Given this list of marker genes KRTAP20-2, CBX6, CDIPT, CNTN2, NAA60, BORCS6, LAMA3, IL22, HOXA2, SSH3, BMAL1, NR1D1, PAX6 (paired box 6), SZT2, HOXC5, GJC1, PTBP3, SLC7A10, INO80, IER5, MIR22HG, TRIB1, PHPT1, LHX6, HYAL2, YRDC, RFX5 (NCBI Gene Id 5993), FHL2 (NCBI Gene Id 2274), IL10, KRT72, ALDH3A1, DSCAM, BIRC3, KCNQ4, LINC03122, NKRF, CLUL1, CCKAR, BCL6, OSBPL6, MPP2, EDEM1, SFRP1, ABCA1, WDFY2, HMG20B, PLAG1, ADD3, HEXD, NR4A1, ACACA, SRF, CEP95, SLC9A9, EMILIN1, CDC14A, DDX5, MAPK10, RNF44, ADAMTS5, HOXD8, SGCA, KDELR2, ACTG2, ACTR1B, VAMP2, ENTR1, NLGN3, DPF3 (NCBI Gene Id 8110), SMARCB1 (NCBI Gene Id 6598), TSPAN3, PMEPA1, KLC2, HAND2, ABCG4, INPPL1, GPC3, NEUROD6, KTN1 (kinectin 1), WDR81, MMP20, TFAP4, ROCK2, DTX1, H2AZ1, CHRDL1, DCP1A, ZBTB47, SIX1, OGFOD3, TMEM38A, ETV6, CHD4, ARHGEF25, ID3, PELO, GSC, YWHAZ, GPX2, IFRD1, TSC22D3, TRPC5, ATP2A2, TBCC, CKAP4, BHLHE22, CRYAB, CDH3, RNF38, MEIS1, CDC25B, FLYWCH1, COL16A1, CNN1, ITGA1, SRPK2, TSC1, PISD (phosphatidylserine decarboxylase), NRXN1, TEKT4, GPR19, POU3F3, CS, PHF12, AXL, PRMT3, GHDC, BTBD3, SRGN, SAP130, ANKS1B, TFEB, ITGA3, MAPKAPK3, FOXE1, NEUROG3, LRR1, OTX1, TRIM28, UNC5C, HPSE2, SLC39A5, HSPB2, HOXB1, GABRB2, SNCAIP, NIN, IRAG1, NIPBL, MYCT1, PLP1, COL15A1, PRDM16, NFIB, POU4F1, ARMCX6, SIDT2, PTK2B, DLX3, FOXP2, ZBTB8OS, NUP54, SZRD1, TLCD4, NKIRAS2, CAPN3, FBXO11, ANGPT1, FKBP8 (NCBI Gene Id 23770), IER2, STX10, MLLT6, KLK7, GPC4, TMCO5A, SMURF2, STK35, ANXA3, PRPS1, UBXN10, TFAP2B, TMEM184B, EGR1, LMNA, SOX3, JMJD1C, TGFB1, PCF11, ETHE1, COL1A1, VASH1, NCDN, CA14, PDIK1L, PHF21B, FRS3, SOX2, CSPG4, ATXN7L1, SYNCRIP, HAPLN3, PPFIA2, MANEAL, HOXA9, BCL7A, DNAJC7, FOSB, KRT36, CCND1, SP8, EPB41, STAG2, RBBP4, JDP2, C2CD2L, ZMYM4, MYH11, TTBK2, VASP, ATXN1, ELAVL1, EP300, HTN1, P3H2, AP4M1, CHRND, ZNF644, MEIS2, PNPLA6, PLCB3, LEP, MMP15 (matrix metallopeptidase 15), MS4A1, EIF5, REEP4, GOLGB1, GABARAPL2, IRX5, ITCH (NCBI Gene Id 83737), PABPN1, MCM7, ZIC2, FGF17, FGF14, VAX1, EPHA1, CCDC88B, PELI2, MCTS1, KCNJ10, NR2F1, PIGR, CD248, TUBB4A, GAN, LUC7L, here is a description of the gene set: Human Gene Set: TFIIA_Q6 species: Homo sapiens Genes having at least one occurrence of the motif TMTRWRAGGRSS in the regions spanning 4 kb centered on their transcription starting sites. This matches the GTF2A1, GTF2A2 transcription factor binding site V$TFIIA_Q6 (v7.4 TRANSFAC).